The following is a description of a gene set: studied in species Mus musculus Mouse Gene Set: GOBP_NEGATIVE_REGULATION_OF_ACTION_POTENTIAL Any process that stops, prevents, or reduces the frequency, rate or extent of action potential creation, propagation or termination. This typically occurs via modulation of the activity or expression of voltage-gated ion channels., and this is the list of marker genes: Cnr1, Gpr35, Chrnb2, Cnr2, Cntnap2, Bin1, Hcn1, Kcnc4, Sumo1 (small ubiquitin-like modifier 1), Scn9a